The following is a description of a gene set: Genes having at least one occurrence of the motif TNYTGGGAATACC in the regions spanning 4 kb centered on their transcription starting sites. This matches the transcription factor binding site V$IK3_01 (v7.4 TRANSFAC). species: Homo sapiens Human Gene Set: IK3_01, and this is the list of marker genes: LCN10, XPO1 (exportin 1), PRICKLE3, ACTN1, CEPT1, CXCL5, TRAPPC3, EPPIN (NCBI Gene Id 57155), FGF17, DNAH9, FAM117A, SDHAF2, C1S, DIO2, JAG1, DBNDD2, PPP2R2B, TSKU, SLC22A11, GRAMD1C (GRAM domain containing 1C), CCDC3, PRR11, SEMA3A, MRTFA, FOS, LMX1A, PPP1CB, ZNF362, PARP8, EHF, ARHGAP29, WSB2 (WD repeat and SOCS box containing 2), TYRO3, RBX1, EGR3, AP1G2, KCNA4, UBXN4, VAMP3 (vesicle associated membrane protein 3), ACE2, HOXB4, TINAGL1 (tubulointerstitial nephritis antigen like 1), ZEB1, ST13P5, KIRREL2, APBA1, VSNL1, SERPINI1, STAG2, FRMD4A, TIMP3, HCN3, SLC50A1, BEST3, HMGA2, PCF11, TLCD3B, VEZF1, PAN2, TAL1, INKA2, NFKBIA, CEP120, TBXT, HECTD1, MSX1, FGF20, RHOQ, CHRNB2, HCST, ADGRB3, THAP8, NSD1, MKNK2, TGIF2, E2F4, LIFR (NCBI Gene Id 3977), FLNC, TSC22D3, AAMDC, ETV6, IGFALS, GABBR1, ACOT9, RTN1, TNFRSF21, TSC22D1, DHRS4, CCL20, WNT3, EIF4A2, CBX8, SIX5, SLC38A5 (solute carrier family 38 member 5), PROK2, EDEM1, PLPP3, RABGAP1L (NCBI Gene Id 9910), CDK9, MECP2, RBBP9, SLIT3, CCN1, NFKBID, ARK2N, UPP2, CA10, JPT2, RCOR2, AMMECR1, KIFC3, NAPG, PNKD, MADD, MAP1LC3A, ZC3H11A, MAP3K13, GABRB1 (gamma-aminobutyric acid type A receptor subunit beta1), CADM1, SH3BGRL2, MAG, SPIB, SLC44A1, KCNJ13, OTX1, ARAP3 (NCBI Gene Id 64411), TFAP2A, ESM1, TNNI2, SCML4, NHLH2, TNFSF18, MTSS1 (MTSS I-BAR domain containing 1), CCDC148, MBNL2, SRPX2, EXOC3L1, GNAO1, KCNH2, CLASRP, PSD, MAP4K4, CD40, MDP1, RHBDF1, PATL1, CHST8, STARD3, SNX16, LHX9, MPLKIP, C2, BAZ2B, IL11RA (interleukin 11 receptor subunit alpha), ANK3, SLITRK1, ASIC1, POLR2B, MMP1, CXCL6, RTL9, PDCD10, DNAJB8, TJAP1, SYNPR, LRRC8E, CYP17A1, ADAM15, RAB11B, FGF10, USP25, PTGES, PRRX1, POU4F2, EGR1, PRRT2, NOA1, SALL1, SP6, DCX, CNTN4, CPSF7, STARD8, CHAD, C12orf50, TRPM3, SLC26A7, PURA, BTF3P11, EVI5L, HOXB9, SLC26A6, CD3E, GRIN2B, RAMP2, NEDD1, TMC4, BCAM, IGDCC3, RNF43, BNC2, NNMT, USP34, ARMH3, SKA2, HIVEP1, SLC30A3, OSBPL7, RGS5, MMS22L (MMS22 like, DNA repair protein), MYT1, CLRN1, RSF1, ST13P4, ARPC2, PKP4, SMPX, AMBN, GATA3, SIRT6, SLC6A9, SUGCT, TMEM88, EPB41, WDR62, LRP2BP, ASCL3, OLFML1, PCDH10